Given this list of marker genes Nos3, Oga, Errfi1, Foxo1, Pparg, Klf4, Igfbp5, Atp2b4, Nol3, Smad3, Mtor, Lmna (lamin A), Mlip, here is a description of the gene set: Mouse Gene Set: GOBP_NEGATIVE_REGULATION_OF_MUSCLE_ADAPTATION species: Mus musculus Any process that stops, prevents, or reduces the frequency, rate, or extent of muscle adaptation.